The following is a description of a gene set: species: Homo sapiens Any process that activates or increases the frequency, rate, or extent of type I interferon production. Type I interferons include the interferon-alpha, beta, delta, episilon, zeta, kappa, tau, and omega gene families. Human Gene Set: GOBP_POSITIVE_REGULATION_OF_TYPE_I_INTERFERON_PRODUCTION, and this is the list of marker genes: MYD88, RIOK3, DDX3X, POLR3B, XIAP, RNF135, RIGI, GAPDH, TRIM65, DHX9 (NCBI Gene Id 3450), UAP1, NMBR, ARRDC4, TOMM70, POLR3A, TANK, PTPN11, TRAF3, TRIM56, HMGB2, MMP12, POLR3G, ZBTB20, POLR3F, STAT1, SYK, TLR4, CLEC12A, IRAK1, STING1, TLR2, G3BP1, IRF7, MAVS, TICAM1, ZC3HAV1, TRAF6, NMB, ZCCHC3, IKBKE, KPNA2, TLR9, HSP90AA1, PQBP1, PTPN22, TRAF3IP3, PLCG2, FLOT1, POLR3D, CGAS, TLR3, IFIH1, CHUK, RAB2B (RAB2B, member RAS oncogene family), POLR3C, OAS3, RIPK2, TLR8, DHX33, ISG15, USP22, SETD2, CD14, TICAM2 (TIR domain containing adaptor molecule 2), IRF1, TBK1, GARIN5A, IRF5, TRIM15, OAS1, HSPD1, OAS2, DHX58, IRF3, DHX36, HMGB1, TLR7